The following is a description of a gene set: Mouse Gene Set: chr9E4 studied in species Mus musculus, and this is the list of marker genes: Gm24338, Ppp2r3a, Msl2, Gm3096, Pccb, Gm3121, Gm28979 (NCBI Gene Id 102633035, predicted gene 28979), Gm5161